The following is a description of a gene set: Genes down-regulated in comparison of T follicular helper (Tfh) cells versus Th1 cells. species: Homo sapiens Human Gene Set: GSE11924_TFH_VS_TH1_CD4_TCELL_DN After activation, CD4+ helper T (Th) cells differentiate into distinct effector subsets. Although chemokine (C-X-C motif) receptor 5-expressing T follicular helper (Tfh) cells are important in humoral immunity, their developmental regulation is unclear. Here we show that Tfh cells had a distinct gene expression profile and developed in vivo independently of the Th1 or Th2 cell lineages. Tfh cell generation was regulated by ICOS ligand (ICOSL) expressed on B cells and was dependent on interleukin-21 (IL-21), IL-6, and signal transducer and activator of transcription 3. However, unlike Th17 cells, differentiation of Tfh cells did not require transforming growth factor b (TGF-b) or Th17-specific orphan nuclear receptors RORa and RORg in vivo. Finally, naive T cells activated in vitro in the presence of IL-21 but not TGF-b signaling preferentially acquired Tfh gene expression and promoted germinal-center reactions in vivo. This study thus demonstrates that Tfh is a distinct Th cell lineage. from publication Nurieva RI, Chung Y, Hwang D, Yang XO, Kang HS, Ma L, Wang YH, Watowich SS, Jetten AM, Tian Q, Dong C (PMID 18599325), and this is the list of marker genes: LRRTM1, VRTN, NEURL1B, APOA2, CCDC43, TRIM28, DNAAF4, PPIL1, PTPN3, RBMX2, SMC1A, TEDC2, RSPO2 (R-spondin 2), AP1S1, CMBL, ACSL5, SPECC1 (sperm antigen with calponin homology and coiled-coil domains 1), GTF2E1, CIMIP5, XKR4, LAP3 (NCBI Gene Id 5186), REEP4, SRP72, YTHDF2, GUCY2D, ACO2, MKKS, C17orf75, DNAJC5B, MSRA, ALDH1B1, CMTR2, TFF2, RAB1A, SUPT3H, PFAS, PCCA, ORMDL2, EMC6, COPS6, CAPN8, NSFL1C, TMEM104, MSANTD4, HAUS5, TBX3, EPSTI1, ODAD4, CPSF6, SLC14A2, CCNY, NMUR1, PSMD11, TGM5, NOC2L, SNRPD3, FSTL4, ANKRD49, MARCHF4, PCNA (proliferating cell nuclear antigen), PSMD6, KLHL11, DENR, RPL7A, MYBPH, SPMAP2, ZC3H8, DGKE, RAE1, MPPED1, STT3B, IRX1, MMAB, EIF3E, SKP2, GAA, CCDC51, SSR3, ZNF706, INAVA, POLR1E, ERP29, GEMIN2, DKK1, MRPS16, PCNX4, HTR1F, C5orf47, TFF3, SPATA7, TGM3, GRIP2, TECTA (NCBI Gene Id 7007), CCDC160, PYCR3, MTRF1L, TXLNB, TSNAX, HAUS4, ARL1, TMEM11, PRKRIP1, TTL, ZNF511, HSP90AA1, MRPS2, TUBB, ZNF516, NDUFB5, ZSCAN12, NOP2, EFNB1, NPR3, RRP12, XPO1, GNPNAT1, NPR1, PFDN1, SEPHS2, NPL, GOLIM4, BOC, SLFNL1, LBX1, LGALSL, SOCS6, PPM1J, PRELID3A, HK3, C9orf152, RPL6, EIF1AX, PRORP, ATPAF2, HEXD, SRP19, SLC16A7, ELP3, CYS1, HSPE1, RTCA (RNA 3'-terminal phosphate cyclase), SPNS3, DNAJC24, HEATR1, CCT8, TRIM44, ODAD3, FOLR1, CACNA1C, ZP1, KCNE3, TAF12 (NCBI Gene Id 6883), GPR27, LRIG3, EXOSC1, EPOR, PRPF4, SCFD1, JADE3, INTS10, TMEM120B, F13B, WTIP, GJD4, MBD3, CENPV, C3orf18, CHAF1B, FCMR, KRT33B, MRPS18A, GYG1, KCTD4, ACSL4, UBE2K, SPARC, SLC4A3, NEPRO, PAXIP1, RDH10, EEF1AKMT2, DLD, CD8B, CFAP53, PPIE, NFYB, TSPAN7, NABP1, ELMOD1, NOL3, DCLRE1B (NCBI Gene Id 64858), USP43, MRPS27, BICD2, CADM1, MPP4, VPS50, POMGNT1, VPS29, IQCF1